Given this list of marker genes PINK1, SPTAN1, SNCA (NCBI Gene Id 6622), SYNJ1, PRKN, LRRK2, ZNF365, CRH, DNAJC6, SMO, FTL, PARK7, TRANK1, NEFL, TNFSF4, AIP, PODXL (podocalyxin like), KCNT1, UCHL1, DEPDC5, CNBP, ATXN7, MOG, CHRNB2, CTSH, MTFMT, SIM1, HLA-DQB1, P2RY11, MAGEL2, HCRT, GPR101, SLC25A13, HTRA2, DNMT1, CHRNA2, PTPA, MFN2, CHCHD2, HLA-DRB1, TFAP2B, FXN, CHRNA4 (NCBI Gene Id 1137), CABP4, VPS13C, here is a description of the gene set: studied in species Homo sapiens Parasomnia An undesirable physical event or experience that occurs during the process of falling asleep, while asleep, or when waking up from sleep. Human Gene Set: HP_PARASOMNIA